Given this list of marker genes PDE3B, ATP6V1E1, GAB2, MAPK1, ATP6V1A, FGF19, FGFR3, AKT2, FGF17, FGF20, ATP6V1E2, ATP6V1F, FGF2, FGF22, ATP6V0E1, ATP6V0B, PIK3CA, ATP6V0A2, INSR, ATP6V1G3 (NCBI Gene Id 127124), PIK3R2 (phosphoinositide-3-kinase regulatory subunit 2), ATP6V1C2, FGF16, PTPRF, SOS1, ATP6V1B2, ATP6V0D1, PDPK1 (3-phosphoinositide dependent protein kinase 1), FRS2, ATP6V0C, PIK3C3, FGFR4, FLT3, FGF23, FGFR1, ATP6V0D2, FGFR2, KLB, TRIB3, SHC1, ATP6V0A4, FGF7, HRAS (NCBI Gene Id 338029), FGF3, IDE, ATP6V1D, PTPN11, TLR9 (NCBI Gene Id 54106), FGF6 (fibroblast growth factor 6), GRB10, PIK3R1, FGF18, ATP6V1B1, NRAS, KRAS, FGF9, ATP6V1C1, PIK3CB, FGF1, FGF10, THEM4, FGF4, FGF5, ATP6V1G1, PIK3R4, TCIRG1 (T cell immune regulator 1, ATPase H+ transporting V0 subunit a3), GRB2, IRS1, CTSD, ATP6V0A1 (NCBI Gene Id 535), IRS2, KL, MAPK3, ATP6V1H, ATP6V1G2, GAB1, FGF8, ATP6V0E2, ATP6AP1, FLT3LG, INS, PTPN1, here is a description of the gene set: Reactome Pathway: Signaling by Insulin receptor part of: Signaling by Receptor Tyrosine Kinases Insulin binding to its receptor results in receptor autophosphorylation on tyrosine residues and the tyrosine phosphorylation of insulin receptor substrates (e.g. IRS and Shc) by the insulin receptor tyrosine kinase. This allows association of IRSs with downstream effectors such as PI-3K via its Src homology 2 (SH2) domains leading to end point events such as Glut4 (Slc2a4) translocation. Shc when tyrosine phosphorylated associates with Grb2 and can thus activate the Ras/MAPK pathway independent of the IRSs.<p>Signal transduction by the insulin receptor is not limited to its activation at the cell surface. The activated ligand-receptor complex initially at the cell surface, is internalised into endosomes itself a process which is dependent on tyrosine autophosphorylation. Endocytosis of activated receptors has the dual effect of concentrating receptors within endosomes and allows the insulin receptor tyrosine kinase to phosphorylate substrates that are spatially distinct from those accessible at the plasma membrane. Acidification of the endosomal lumen, due to the presence of proton pumps, results in dissociation of insulin from its receptor. (The endosome constitutes the major site of insulin degradation). This loss of the ligand-receptor complex attenuates any further insulin-driven receptor re-phosphorylation events and leads to receptor dephosphorylation by extra-lumenal endosomally-associated protein tyrosine phosphatases (PTPs). The identity of these PTPs is not clearly established yet. species: Homo sapiens